Given this list of marker genes UXS1, RPIA, G6PD, NUDT5, FGGY, DCXR, DHDH, OTOGL, OTOG, XYLB, RBKS, FKRP, PGD, here is a description of the gene set: The chemical reactions and pathways involving a pentose, any monosaccharide with a chain of five carbon atoms in the molecule. studied in species Homo sapiens Human Gene Set: GOBP_PENTOSE_METABOLIC_PROCESS